The following is a description of a gene set: TRIF (TICAM1) was shown to induce IRF3/7 and NF-kappa-B activation as well as apoptosis through distinct intracellular signaling pathways (Yamamoto M et al., 2003; Fitzgerald KA et al., 2003; Han KJ et al., 2004; Kaiser WJ & Offermann MK 2005). <p>TRIF consists of an N-terminal domain (NTD) (1-153), an intermediate disordered proline-rich region, a TIR domain, and a C-terminal region (Mahita J & Sowdhamin R 2017). The disordered proline-rich region between NTD domain and the TIR domain of TICAM1 contains binding sites for TRAF (TNF receptor associated factor) family proteins, which, in turn, recruit protein kinases to promote activation of IRF3 and/or NF-kappa-B (Sato S et al., 2003; Fitzgerald KA et al., 2003). The C-terminal region of TICAM1 (TRIF) can recruit receptor-interacting serine/threonine-protein kinase 1 (RIPK1), and this event is followed by the activation of the IKK complex or the induction of programmed cell death (Han KJ et al., 2004; Kaiser WJ & Offermann MK 2005). part of: MyD88-independent TLR4 cascade  Reactome Pathway: TRIF (TICAM1)-mediated TLR4 signaling species: Homo sapiens, and this is the list of marker genes: IRAK1, UBE2D3, AGER, UBE2V1, LY96, MAPK9, IRF3, IKBKE, IKBKG, NFKBIA, TAB2, TP53, MAP3K7, MAPK11, RPS6KA2 (NCBI Gene Id 6196, ribosomal protein S6 kinase A2), HMGB1, IRAK2, OPTN, IRF7, NFKB1, MEF2A, CHUK, MAPK7, TRAF3, FOS, APP, TAB3, RIPK3, TICAM2, TICAM1, TAB1 (NCBI Gene Id 10454), UBC, FADD, IKBIP, PPP2CB, USP14, MAP2K6, MAP2K4, PPP2R5D, UBB, SKP1, DUSP4, TANK, PTPN11, MAP3K8, ALPK1, USP18, MAP2K1, RIPK2, MAPK3, MAPK8, MEF2C, NKIRAS2, DUSP7, ATF2, PPP2R1A, NKIRAS1, ELK1, NFKB2, UBE2D1, MAPKAPK2, DUSP3, TLR4, N, RPS6KA3, NFKBIB, MAPK1, N4BP1, IKBKB, RELA, SAA1, NOD1, BIRC2, RIPK1, MAPK14, VRK3, PPP2R1B, MAP2K3, TRAF2, RPS6KA5, RPS6KA1, SARM1, RPS27A, BIRC3, CASP8, JUN (NCBI Gene Id 3725), UBE2D2, NLRC5, DUSP6, FBXW11, MAP2K7, CD14, TBK1, NOD2, CUL1, BTRC, NLRX1, UBE2N, UBA52, TIFA, ATF1, S100B, TRAF6, PPP2CA, MAPKAPK3, MAPK10, S100A12, LRRC14, CREB1, TNIP2